The following is a description of a gene set: Human Gene Set: GOCC_DOPAMINERGIC_SYNAPSE A synapse that uses dopamine as a neurotransmitter. studied in species Homo sapiens, and this is the list of marker genes: CHRNA5, SLC6A3, SLC18A2, NLGN2, RAB3B, CHRNA6, SV2C, DRD2, ADRA2A, SEPTIN4, CHRNB3, VPS35, PRKN, SYT11, FLOT1